Given this list of marker genes SMAD4, CCNG2 (NCBI Gene Id 901), CDKN1A, FOXO4, CAV1, CDKN1B, MSTN, FOXG1, KLF4, FOXO1, SMAD3, SMAD2 (NCBI Gene Id 654050), PCBP4, GADD45A, BTG1, RBL2, FOXO3, here is a description of the gene set: part of: FOXO-mediated transcription studied in species Homo sapiens Reactome Pathway: FOXO-mediated transcription of cell cycle genes FOXO transcription factors induce expression of several genes that negatively regulate proliferation of different cell types, such as erythroid progenitors and neuroepithelial progenitor cells in the telencephalon.<br>Transcription of cyclin-dependent kinase (CDK) inhibitors CDKN1A (p21Cip1) is directly stimulated by FOXO1, FOXO3 and FOXO4. FOXO transcription factors can cooperate with the SMAD2/3:SMAD4 complex to induce CDKN1A transcription in response to TGF-beta signaling.<br>FOXO transcription factors FOXO1, FOXO3 and FOXO4 stimulate transcription of the CDKN1B (p27Kip1) gene, but direct binding of FOXOs to the CDKN1B gene locus has not been demonstrated.<br>FOXO3 and FOXO4, and possibly FOXO1, directly stimulate transcription of the GADD45A gene.<br>Transcription of the retinoblastoma family protein RBL2 (p130), involved in the maintenance of quiescent (G0) state, is directly stimulated by FOXO1, FOXO3 and FOXO4.<br>Transcription of the anti-proliferative protein CCNG2 is directly stimulated by FOXO1 and FOXO3, and possibly FOXO4 (Martinez Gac et al. 2004, Chen et al. 2006). Transcription of the anti-proliferative protein BTG1 is directly stimulated by FOXO3.<br>Transcription of CAV1, encoding caveolin-1, involved in negative regulation of growth factor receptor signaling and establishment of quiescent cell phenotype, is directly stimulated by FOXO1 and FOXO3 (van den Heuvel et al. 2005, Roy et al. 2008, Nho et al. 2013, Sisci et al. 2013).<br>FOXO1 and FOXO3 promote transcription of the KLF4 gene, encoding a transcription factor Krueppel-like factor 4, which inhibits proliferation of mouse B cells.<br> FOXO1, together with the p-2S-SMAD2/3:SMAD4 complex, stimulates transcription of the MSTN gene, encoding myostatin, a TGF-beta family member that stimulates differentiation of myoblasts.